The following is a description of a gene set: from publication Toker A, Engelbert D, Garg G, Polansky JK, Floess S, Miyao T, Baron U, Düber S, Geffers R, Giehr P, Schallenberg S, Kretschmer K, Olek S, Walter J, Weiss S, Hori S, Hamann A, Huehn J (PMID 23420886) We investigated at which stage of maturation commitment to a stable Foxp3-expressing phenotype takes place. We assessed stability of Foxp3 expression in thymic Foxp3+ Treg subsets of different maturity, defined by CD24 expression. Next we compared gene expression profiles of Foxp3+ Treg subsets (+) of different maturity (24lo, 24int, 24hi) and could identify a set of genes that were specifically up or downregulated in Foxp3+ Tregs, but not in Foxp3- conventional T cells, in a maturation-dependent manner. Genes down-regulated in thymic T reg: CD24 high versus CD24 low. Human Gene Set: GSE42021_CD24HI_VS_CD24LOW_TREG_THYMUS_DN studied in species Homo sapiens, and this is the list of marker genes: ETS2, FBLN5, CASP7, ISG15, HLA-A, IL20RA, BCL2L13, PHACTR4, AUTS2, RSAD2, JADE2, DDX60, IFIT5, PLSCR1, NAT8B, TLR3, SP140L, SELL, NKX3-1, HES2, RBBP6, ZNF419, TRIM5, CMTR1, LUM, SERPING1, CCL22, ELF1, GJD2 (NCBI Gene Id 57369), MX1, CBLN1, MBIP (MAP3K12 binding inhibitory protein 1), ZNF93, CXCL11, HLA-C, BST2, LAMP3, CCNK, PML, KDM5C, CBR3, ADGRE5, ANK1, GBX1, MUC4, PCLO, GCH1, FMR1, TNFSF10, LAP3, MECP2, IRF9, PLSCR4, IFI6, FRS3, HIPK3, TOP1, TMEM140, MYD88, ZNF672, LRRC17, FOXD2, RBCK1, KIAA0408, SIX1, TEF, TRIM14, CLUHP3, TDRD7, IFI44L, KLK6, TRANK1, SPATS2L, KIFBP, DLG2, HERC5, THEMIS2, KCTD14, RASGRP3, PIK3CA, BATF3, TENT5A, CFB, BRAF, STAT5A, ADARB1, CKB, NAPA, STOML1, CXCL10, ERAP2, VN1R1, OAS3, FST, GTF2B, MTCL2 (NCBI Gene Id 90072), RRAGC, TLK2, ENSG00000284948, PARP12, LMO2, RAPGEF6, IFIT2, DSP, PHF11, CD164, BMPR2, PPAT (NCBI Gene Id 5471), OASL, SERPINA4, DAPP1, TRIM38, IFI27, XAF1, OAS1, CNP, H2AC25, EIF2AK2 (eukaryotic translation initiation factor 2 alpha kinase 2), MX2, SP110, SHFL, CCT8L2, LRFN3, HEG1, IFIT1, KLHL35, NDUFA9 (NADH:ubiquinone oxidoreductase subunit A9), SLC5A7, TNFAIP3, GATA3, IFITM2, RIGI, KANK1, LEP, TSSK1B, RNF19B, GATA6, HERC6, EGLN1, ATP10A, IFI35, USP18 (NCBI Gene Id 11274), MUC16, FPR3, SLC35F6, SP100, LGALS13, IFI44, OAS2, SPACA9, WT1, CDK17, HRH2, CREM, GUSBP14, FLRT3, HLA-B, IFI16, DPYD, ISG20, IGFBP3, TREX1, CHMP5, MPPED1, HLA-F, SLC25A28, MSX1, SLC22A11, CEACAM1, TTF2, TGS1, PRKD2, PTPRZ1, SLC16A8, NREP, CELP, ATF3, IFIT3, MYH1 (NCBI Gene Id 4619), IFITM3, ANKRD1, IRF7, PANX1, RNF114, KCTD17, EHD4, IFITM1, SOCS1, TRIM22, RUBCN, SFRP1, EXT1, APOL1 (apolipoprotein L1), ZNF280B, ZNF225, SAMD9, IMPG1, DLX2, IFIH1, TRAFD1